The following is a description of a gene set: Human Gene Set: GSE17721_12H_VS_24H_CPG_BMDC_UP Genes up-regulated in comparison of dendritic cells (DC) stimulated with CpG DNA (TLR9 agonist) at 12 h versus those stimulated with CpG DNA (TLR9 agonist) at 24 h. studied in species Homo sapiens mouse primary BMDCs were stimulated with tlr ligands and gene expression changes were profiled on Affymetrix arrays from publication Amit I, Garber M, Chevrier N, Leite AP, Donner Y, Eisenhaure T, Guttman M, Grenier JK, Li W, Zuk O, Schubert LA, Birditt B, Shay T, Goren A, Zhang X, Smith Z, Deering R, McDonald RC, Cabili M, Bernstein BE, Rinn JL, Meissner A, Root DE, Hacohen N, Regev A (PMID 19729616), and this is the list of marker genes: ZFP36, ASB13, USP42, SLC12A3, AR, DNMT3A, ANKRD33B (ankyrin repeat domain 33B), SLC28A2, DPH2, MOV10, HIGD1B, CIAPIN1, TENT5C (terminal nucleotidyltransferase 5C), CASP3, PKMYT1, HLA-G, IFT22, PAH, RHOC, RSAD2, PHKG1, ANXA11, MKI67, BDKRB2, SUN2, NECTIN2, MUC4, SMAD2, MARCHF5, AKNA, CER1, UBA7, RUFY3, HMGCL, HEBP1, GART, TSC22D1, CHRNA5, GREM2, NCOA4, SMPD3 (sphingomyelin phosphodiesterase 3), PTGER4 (prostaglandin E receptor 4), BHLHE41, BRWD3, PLAAT3, SLAMF8, IL15, RPP25, CATSPERG, TYROBP, ENDOD1, CLEC10A, MET, CREB3 (cAMP responsive element binding protein 3), FAM20C, AP2B1, WDFY2, HPX, SNAP29, CCL13, TNFAIP2, WDR43, UCN, SENP1, FBXO6, RAD23B (NCBI Gene Id 5887), CDC27, INTS8, UBD, SHARPIN, TTC39B, REEP6, ADAMTSL5, EGFL8, C19orf12 (NCBI Gene Id 83636), SNX2, BATF2, SLC31A2, PSMB9, SEMA3A, SLC30A3, UTP11, SMARCD3, SLFN12, PTGES, CHODL, UXT, RSPRY1 (ring finger and SPRY domain containing 1), F10, LTA, SLC6A4, KANK2, F2RL2, FAS, GRM1, ECE1, EFNA3, G3BP2, PMP22, TRIB1, IFT172 (intraflagellar transport 172), USP12, CXADR, RNF6, SERPINE2, C6orf62, HEYL, THOC6, NTSR2, IFIH1, ELP5, TUT7, PPP1R14D, TARDBP, PHGDH, EXOC6, PHACTR1, ASTE1, GCOM1, GPR83, TIRAP, TNFAIP8L1, TCF7L1, AP1AR, LGR5, CCNL1, SNAP23, TSLP, RGS10, IGF1, CDKN2C, ZUP1, CIITA, PARM1, NKIRAS2, IL1A, PNPT1, PPP2R5A, CD40, CWC15 (NCBI Gene Id 51503), PSMB6, EZR, GBP6 (guanylate binding protein family member 6), TFG, SEPTIN8, CSRP3, APLNR, SLC25A48, LBX1, TFEC, GNGT1, CARHSP1, ACOT4, LDB3, ID1 (NCBI Gene Id 96820), ETV4, PDZRN3, LIPG, ZDHHC20, SPIC, TOB2, ALDH18A1, TBC1D13, ALDH1A2, ASPDH, RAPGEF3, SPRY1, SOSTDC1, FST, PLGRKT, CACNG5, KITLG, DNAJB1, PIK3R1, WNK2, LGALS8, NDUFS8, RAB29, CLIC4, SLC1A3, CYP11B2, CCDC86, TMEM184A, CLIC3, RGL1, GCG, ANXA4, MITF, RPS6KA4, PEAR1, HMGCS1, SST, RBFOX1, SLC35F6, MSR1, TBATA, PHLDB1, TCIRG1, CHMP4B